Given this list of marker genes MSTN, EPHB1, AKIRIN1, SIX5, CAV2, here is a description of the gene set: Any process that stops, prevents, or reduces the frequency, rate or extent of skeletal muscle cell proliferation. species: Homo sapiens Human Gene Set: GOBP_NEGATIVE_REGULATION_OF_SKELETAL_MUSCLE_CELL_PROLIFERATION